Given this list of marker genes Mtm1, Nras, Hdac5, Sox15, Cenpf, Hdac9, Cdon, Tcf7l2, Usp2, Actn3, Wnt10b, Shox2, Hdac7, Gja1, Myf5, Adrb2, Igf2, Tgfb1, Flot1, Bcl2, Sfmbt1, Myog, Creb1, Smad3, Mrtfb, Prkaa1, Dll1, Sirt2, Mir214, Bdnf, Ybx3, Rps6kb1, Ctnnb1, Lef1, Rpl3l, Twist1, Mef2c, Myf6, Tifab, Wnt3a, Neurog1, Boc, Fgf8, Jph2, Shh, Il6, Hmgcr, Luc7l, Bmp4, Erbb3, Fgf3, Myod1, Megf10, Lmod3, Usp19, Lox, here is a description of the gene set: Mouse Gene Set: GOBP_REGULATION_OF_MUSCLE_ORGAN_DEVELOPMENT studied in species Mus musculus Any process that modulates the frequency, rate or extent of muscle development.